The following is a description of a gene set: Human Gene Set: HP_THICK_UPPER_LIP_VERMILION Thick upper lip vermilion Height of the vermilion of the upper lip in the midline more than 2 SD above the mean. Alternatively, an apparently increased height of the vermilion of the upper lip in the frontal view (subjective). species: Homo sapiens, and this is the list of marker genes: COL11A1, NAA10, MINPP1, NOG, THOC6, ABCC9, KDM6A, KDM4B, WDR26, APC, TOE1, GPC4, KMT2D, DENND5A, NAA20, EBF3, DVL1, CDK13, BRCA1, TMEM53, SC5D, PAK3, TWIST2, VPS51, CILK1, STRADA, NSUN2, AFG2B, RPS7